Given this list of marker genes MFNG, CCNI, IFITM1, CASP4, IFNAR2, FAS, MYC, GSTM2, CDK4, PDCD2, TFAP4, SLC2A5, DAD1, VCL (vinculin), MYB, CDKN3, TWF1, TYMS, here is a description of the gene set: from publication Wu CG, Salvay DM, Forgues M, Valerie K, Farnsworth J, Markin RS, Wang XW (PMID 11439330) Human Gene Set: WU_HBX_TARGETS_3_UP species: Homo sapiens Genes up-regulated by expression of HBV X protein (HBVgp3) both in SK-Hep-1 cells (hepatocellular carcinoma) and normal primary hepatocytes. Hepatitis B virus (HBV) is a major risk factor for the development of hepatocellular carcinoma (HCC). HBV encodes the potentially oncogenic HBx protein, which mainly functions as a transcriptional co-activator involving in multiple gene deregulations. However, mechanisms underlying HBx-mediated oncogenicity remain unclear. To determine the role(s) of HBx in the early genesis of HCC, we utilized the NCI Oncochip microarray that contains 2208 human cDNA clones to examine the gene expression profiles in either freshly isolated normal primary adult human hepatocytes (Hhep) or an HCC cell line (SK-Hep-1) ecotopically expressing HBx via an adenoviral system. The gene expression profiles also were determined in liver samples from HBV-infected chronic active hepatitis patients when compared with normal liver samples. The microarray results were validated through Northern blot analysis of the expression of selected genes. Using reciprocally labeling hybridizations, scatterplot analysis of gene expression ratios in human primary hepatocytes expressing HBx demonstrates that microarrays are highly reproducible. The comparison of gene expression profiles between HBx-expressing primary hepatocytes and HBV-infected liver samples shows a consistent alteration of many cellular genes including a subset of oncogenes (such as c-myc and c-myb) and tumor suppressor genes (such as APC, p53, WAF1 and WT1). Furthermore, clustering algorithm analysis showed distinctive gene expression profiles in Hhep and SK-Hep-1 cells. Our findings are consistent with the hypothesis that the deregulation of cellular genes by oncogenic HBx may be an early event that favors hepatocyte proliferation during liver carcinogenesis.